The following is a description of a gene set: Human Gene Set: GOBP_OSSIFICATION species: Homo sapiens The formation of bone or of a bony substance, or the conversion of fibrous tissue or of cartilage into bone or a bony substance., and this is the list of marker genes: GLI2, NAB1, FOXC2, ECM1, TRAF6, COL1A2, ERCC2, HIF1A, PEX7, ACVR1B, NIPBL, COMP, CTNNBIP1, UCMA, P2RX7, CASR, ACHE, PTCH1, WWTR1, MIR100, TNFSF11, WNT5A, HNRNPC, WWOX (WW domain containing oxidoreductase), SHOX2, IPO7, ACTN3, PTH, BMP7, PBX1, SFRP1 (secreted frizzled related protein 1), MIR27A, HERC1, YAP1, TGFB1, HSPE1, ZMPSTE24, TMEM53, RSPO2, MDK, TMEM64, ALOX5, FHL2, DHX9, SUCO, ATP2B1, SOX9, MATN1, IL6, RSL1D1, ID3, FGFR2, MAP2K6, CBS, WNT4, ENSG00000274276, BMP2K, MIR140, CLEC3A, TAC1, IGF2, CLEC11A (C-type lectin domain containing 11A), VEGFC, UFL1, MIR98, RHOA, TAOK3, H3-3B, MIR125B1, ADCY10, RRBP1, RANBP3L, CRIM1, TWIST1, SMAD7, RBPJ, MIR29B1, COL13A1, ISG15, MIR21, HSD17B4, NAB2, ADGRV1, DHX36, IFT80, REST (NCBI Gene Id 5978), ACVR2A, FGFR3, TWIST2, OSR1, RIPPLY2, NPPC, GABBR1, DKK1 (NCBI Gene Id 22943), PHEX, IGF1, PHOSPHO1, ALOX15, TNC, CER1, SMAD4, HEMGN, MIR106A, DLX5, CCN2, BMP6 (NCBI Gene Id 7964), CDK6, CCDC47, BMPR2, CSF1, FBXL15, TPM4, GDF2 (growth differentiation factor 2), PENK, CEBPA, MGP, TNFAIP6, CREB3L1, ATRAID, FSTL3, SEMA7A, STC1, MAPK14, TNN, SUV39H1, SMAD9, ADAMTS7 (ADAM metallopeptidase with thrombospondin type 1 motif 7), MRC2, BMP8A, INTU, GDF5, NR1I3, FKRP, DMP1, TUFT1, IHH (Indian hedgehog signaling molecule), ANO6, CTHRC1, WNT7B, ALYREF (Aly/REF export factor), CLIC1, MINPP1, SLC34A1, MIR9-1, PLXNB1, MYOC, TOB1, NPR2, ASF1A, BMPR1A, HIRA, JAG1, MAPK3, MIR17, TMT1A, FOXC1, ATP6V0A4 (ATPase H+ transporting V0 subunit a4), DNAI3, GPM6B, GIT1, WNT3, SOX8, KREMEN1, ERFE, SBNO2, PDLIM7, IGSF10, PRKACA, SBDS, FERMT2, INPPL1, SUN1, MIR214, BMP5, RDH14, PRMT3, TCIRG1, MYBBP1A, NELL1, HDAC7, ADRB2, SKI, RORB, RXRA, BPNT2, PRKD1, CCN3, CYP24A1, LEP, GPLD1, AHSG, FASN, SCX, TNF, ATF4, BMP3, MIR24-1, BMPR1B, BGLAP, RXRB, ID2, VDR, MSX2, ADAR, LGR4, FBL, RASSF2, BMP8B, GATA1, CDH11, ROGDI, IARS1, PPARG, KREMEN2, TNFRSF11A, ENPP1, MIR675 (microRNA 675), EGR2, DHRS3, CEBPD, SMAD2 (SMAD family member 2), SOST, TMEM119, TP53INP2, SPP1, XYLT1, GFRA4, TXLNG, SMAD6, PTPN11, MYOG, DHH, CCDC154, PTK2, MIR205, LRRC17 (NCBI Gene Id 10234), TP63, MIR3648-1, SMO, IFITM1 (NCBI Gene Id 8519), SCUBE3, PSMC2, RUNX3, GLI1, NOG, BCAP29, PANX3, LIMD1, ACVR2B, EXT1, SLC8A1, EBP, KL, SATB2, THBS3, PRICKLE1, MMP16, SFRP2, FBN2, SORT1, SMAD3, MIR20A, CAT, THRA, HGF, RRAS2, IGFBP2, MEN1, MMP2, WNT3A, FFAR4, GALNT3, DDX21 (DExD-box helicase 21), COL6A1, MIR200C, HOXA2, EIF2AK3, PAM16, OSTN, RPS15, TENT5A, CCR1, RBMX (NCBI Gene Id 8258), BCL2, CCN4, WNT11, SP7, AREG, OSTF1, IGFBP3, FGF2, SLC24A3, RIOX1, MESD, ZBTB40, PPP3CA, ADAMTS12, ADGRG6, SUFU, OXT, CCL3, GDF10, SNX10, MEF2C (NCBI Gene Id 4208), DCHS1, SP3, LRP3, CEBPB, TACR1, SHH, SGMS2, FGF18, SEMA4D, MIR346, FGF9, JUND, CCDC134, FGR, CHSY1, FAM20C, RYR1, KLF10, CLEC3B, ASPN, PTHLH, RUNX1, MN1, MIR203A, MAPK1, COL2A1, MIR30B, JUNB, ILK, SMPD3, TOB2, BMP2, FBXO5, PTH1R, GDPD2, MAPK11, GPC3, CSGALNACT1, SOX11 (NCBI Gene Id 6664), NOTUM, GREM1, CCN1, PTN, SIRT7, CITED1, WNT10B, ACVR1, SNAI1, GLI3, LOX, SMAD1 (SMAD family member 1), LEF1, SMAD5, TMCO1, MMP13, MIR208A, RPL38, MIR20B, CTNNB1, SMOC1, FIGNL1, EXT2, MYF5 (myogenic factor 5), GSK3B, IGFBP5, TFAP2A, LRP4, NOCT, PHB1, AXIN2, FZD9, STATH, CHRDL2, MIR18A, PTK2B, FGF23, ID4, BMP4, CHRDL1, EGFR, MIR320A, RFLNB, P3H1, IL6ST, ID1, LRP5, CALCR, RUNX2, IBSP, COL1A1, BAMBI, IL6R, ATP6V1B1, SETD2, LTBP3, VEGFA, DDX5, MIR548D1, SLC20A2 (NCBI Gene Id 6575), SOX2, ZBTB16, SRGN, DDR2 (NCBI Gene Id 4921), AKT1, SNAI2, HNRNPU, H3-3A, TWSG1, KAZALD1, MMP14, ITGA11, IFITM5, CBFB, FOSL2, SNRNP200, PTEN (NCBI Gene Id 8037), EPHA2, TAPT1 (transmembrane anterior posterior transformation 1), SYNCRIP, BMP1, NF1, ALPL, RFLNA, CLTC, PKDCC, BCOR, VCAN, MIR138-1 (microRNA 138-1), CHRD, DNAJC13, TRPM4, CYP27B1, NPNT, SIX2, MIR93, CLEC5A, OSR2, SND1, TMEM38B, S1PR1, AMELX, FZD1, PTPRB, GTPBP4, MIR210, NOTCH1, HAND2, ATP5F1B, ANKH, NBR1, LTF (NCBI Gene Id 4057), ZHX3